Given this list of marker genes ETNK1, ATXN7, SLMAP, ADAMTS5, SESTD1 (SEC14 and spectrin domain containing 1), MFAP3 (microfibril associated protein 3), ARHGAP23, STRN, KHDC4, LGR5 (NCBI Gene Id 8549), INO80D, DMXL2, ZIC1, LARP7, CDYL2, RBM41, PRR16, A1CF, NEGR1, ARL1, TRIM33, PXDC1, PPM1D, SPAG1, FASTKD5, ZNF148, PROSER1, ZNF257 (NCBI Gene Id 113835), AZIN1, NHS, TBC1D23, EMC8, FGD4, POLR2B, TOP2A, RBM25, ZNF608, EMX2, RAB14, NCOA3, IFFO2 (intermediate filament family orphan 2), MKRN3, GRIA2, PTPRM, B3GALT2, PTPRJ, RALGPS2, RAD17, GCLC, CLK2, RALGDS (ral guanine nucleotide dissociation stimulator), PTP4A1, IREB2, DGKH, CHST2, SLITRK6, PRPF40A (NCBI Gene Id 55660), RFX7, SGPP1, ARPP19, CNOT7, KCNA2, MAP3K1, PTPN6, DNAJC10, TMEM33, CYTH3, NXPH2, PABPC4L, JADE3 (NCBI Gene Id 9767), SYT15, C6orf136, CEP350, LRIG2, SAMSN1, OPRK1, MYBL1, AP3M1, PLD3, TFEC, NRCAM, SEL1L3, RBBP6, COG2, PDE1A, HTR2C (NCBI Gene Id 3358), STAT5B, ALG11, FCRL2, NRG1, PAQR3, PHC3, GOLT1B, ATP1A2 (NCBI Gene Id 93186), TBK1, PCDH11Y, KCNAB1, VIP, LRP8, KIAA1217, REXO2, FGF9, RETREG2, ARHGAP18, CGGBP1, RTF1 (NCBI Gene Id 23168), ZNF492 (zinc finger protein 492), NUFIP2, PKN2, RAI2, WRAP73, SLC31A2, SLC9A6, IRX2, RGS7BP, SLC1A1, FAM234B, SLC35E2A, DDHD2, NCOR1, TACC2, ZNF236, NPR2, ABHD13, CLVS2, STRBP, PTPN13, IFIT5, ARID2, B3GALT1, DHX35, LRRK2, BMP3, BCAR3, ANGPT2 (angiopoietin 2), MTSS1, ARHGEF11, MEX3C, GABRG2, PARP8, TTL, DNAAF9, DLG2, EXPH5, GUCY1A2, PNRC1, MRPS23, ARMT1, ZFAND5, PIM2, PLXNA2, RORA, CASD1, MTFR1, FAM181A, EMP1, ZNF33B, KLHL24, ARHGAP32, CHMP7 (NCBI Gene Id 91782), LRRC58, CCDC61, ZIC3, GNL3L, AFG3L2, ARHGAP5, WIPF3, C2orf49, TMEM170B, BORCS7, HYCC2, DHX40, PCDH9 (NCBI Gene Id 57123), STMN2, PHF23, GPR4, POU3F1, CYB5B, CLSTN1, FAM3C, NOG, RASA1, DNAH10, BCL2L11, TTC22, UNC50, VEZF1, SGIP1, PSMB4, ZNF197, TIAL1 (NCBI Gene Id 8430), ZNF532, PIKFYVE, GFPT1, LSM1, RTCA, ASB5, IFT74, FBXO32, SASH1, DACH1, FCHO2, ITPR1, DUSP6, ARL6IP1, STK24, BACH2, PTPN22, VLDLR, NKTR, FAM135B, PIK3CG, DOCK3, HJURP, OCLN, DKK1, OCIAD1, ADRA2A, SAMD8, RAB12, DNAJA3, MARCHF6, CMPK1, CDH6, NF1, NAP1L3, DNAJC6, SKP1, ATMIN, CUL1, FILIP1L, NCBP1, ARL4A, GREB1, HSPA5, MIA2, SACM1L, FOXJ3, PAN3, LNPK, MCRS1, CACNB2, TXNL1, IYD, GBP4, ZMYM2, ZNF516, ING3, LYPD6, SNTG1, UBE2K, FCRL1, PHF3, GLI2, KATNBL1, SLC38A2, DCUN1D1, CXCL8, SLC45A1, CNOT6L, KBTBD3, ITGA8, PDE1C, KAT7, CNOT4, CRY1 (cryptochrome circadian regulator 1), INTS2, HSD17B13, SF3B2, DKK2, DENND5B, PELI1, TRPS1 (NCBI Gene Id 7227), DBF4, GNAQ, ERBB4, TUT7, RNF128, CPSF6, HCN1, SRPX2, P2RY14, ARGLU1, PIP4P2, DICER1, CILK1, SLC35D2, HSPA1A, GOLPH3, RIC1, LTV1, SPTLC2, SVIP, DHX15 (NCBI Gene Id 1665), TRDN, TMEM202, CRLS1, RHOT1, C1orf21, N4BP2L1, RCOR3, SNUPN, RILPL2, PIP5K1B, ELF1, MBNL3, PTPRZ1, GAB1, MSC, MEF2A, SKIL, MYC, ZWILCH, MAP3K2, CSNK1G3, ZNF367, BDP1, NFKB1, RSBN1L, RABGEF1, HECTD2, BBOF1, KIT, PDLIM5, CCN2, ADRA1A, ARL8B (NCBI Gene Id 55207), GRIA3, ADRB2, TMEM41B, KMT2A, RALGAPB, STC2 (stanniocalcin 2), RAPGEF4, MPDZ, LMOD2 (NCBI Gene Id 442721), SIX4 (SIX homeobox 4), CHIC1, NRIP1, VGF, TMEM60, IQCK, LSM14A, TSGA10, PLEKHA1, TUBGCP3, ACTR3B, UBR3, ALDH1L2, CAPN12, APBB2, RICTOR, SLC8A1, TENM1 (NCBI Gene Id 10405), SFSWAP, BRD2, ATP23, NEFL, AP1AR, KCNJ1, HNF1B, TBC1D12, FGFR2, ZCCHC14, EGR3, RAB27A, PLPPR4, UBE2V2 (ubiquitin conjugating enzyme E2 V2), SRP9, KLF5 (NCBI Gene Id 688), DIPK2A, HIPK2, TM9SF2, CENPA, FMNL2, ALG10B, CNEP1R1, CDH10, ABHD10, DCLK1, USP42, PHF13, APC, TGFB2, VAV3, LONRF3, SLC20A2, PTPRB, PCDH11X, RFPL4B, CDK19, ADD3, ADARB2, RAB11FIP2, ADAMTSL3, CCPG1, KIF1B, AP3S1, SLC5A3, USP12, DEUP1, UBA2, STARD13 (StAR related lipid transfer domain containing 13), ELAVL2, KLF3, NIPA1, TMEM220, PRKD3, ZBTB34, FAR2, USH2A, NPAT, FUT9, NLK, CALCRL, PLAC8, RFX3, ZC3H12C, SCAI, KCTD4, MYRF, HOXD8, ZNF704, ATRN, MPV17L, CLVS1, PAWR, ITGB3BP, WDR89, STXBP5, PHAF1 (phagosome assembly factor 1), RBM12B, GABARAPL2, EDEM3, MPP7, PEX2, ARHGAP11A, SLITRK2, VKORC1L1, ANKRD22, LRP6, ZNF407, IL22RA2, TTK, ZIC2, CBFB, TOX, FBXO3, PCNP, RNF169, C1orf52, ASAH1, TYW5, AKAP1, IGFBP3, HYCC1, URI1 (URI1 prefoldin like chaperone), SIMC1, AHCTF1, TLE1, PTPN4, TENT4A, HOOK1, RBM39, MAMDC2, GABRB2, KIF18A, SRSF1, DLC1, DCAF17, GABRA4, INTS6, SELENOK, HBS1L, OLIG3, HLX, BMP6, STX12, SEZ6L2, PSD3 (NCBI Gene Id 55358), SH2D3C, COL5A1, SUZ12, WAPL, SLC27A2, RBM27, KCNJ4, EEA1, here is a description of the gene set: studied in species Homo sapiens Human Gene Set: MIR4699_3P from publication Chen Y, Wang X (PMID 31504780) Genes predicted to be targets of miRBase v22 microRNA hsa-miR-4699-3p in miRDB v6.0 with MirTarget v4 prediction scores > 80 (high confidence targets).